Given this list of marker genes Laptm5 (lysosomal-associated protein transmembrane 5), Cox7a2l, Pid1, Lyz2, Nop53, Hepacam2, Kctd12, here is a description of the gene set: Cytokines mediate cell-cell communication in the immune system and represent important therapeutic targets. A myriad of studies have highlighted their central role in immune function, yet we lack a global view of the cellular responses of each immune cell type to each cytokine. To address this gap, the authors created the Immune Dictionary, a compendium of single-cell transcriptomic profiles of more than 17 immune cell types in response to each of 86 cytokines (>1,400 cytokine-cell type combinations) in mouse lymph nodes in vivo. A cytokine-centric view of the dictionary revealed that most cytokines induce highly cell-type-specific responses. For example, the inflammatory cytokine interleukin-1β induces distinct gene programmes in almost every cell type. A cell-type-centric view of the dictionary identified more than 66 cytokine-driven cellular polarization states across immune cell types, including previously uncharacterized states such as an interleukin-18-induced polyfunctional natural killer cell state. from publication Cui A, Huang T, Li S, Ma A, Pérez JL, Sander C, Keskin DB, Wu CJ, Fraenkel E, Hacohen N (PMID 38057668) Mouse Gene Set: CUI_CDC1_IFNL2_RESPONSE_DN Genes negatively differentially expressed in cell type: cDC1 (conventional dendritic cell type 1) upon treatment with cytokine: IFN-λ2 in mouse lymph nodes in vivo. species: Mus musculus